Given this list of marker genes NR2F1, NWD2, SLC17A5, SLF2, VLDLR, HBEGF, NEXMIF, PLEKHG1, ZNF746 (NCBI Gene Id 155061), FRY, YTHDF1, EDEM1, POLI, WARS1, LIX1L, TMEM135, PDCL, ARFGEF1, PRR23A, IPMK (inositol polyphosphate multikinase), GRIP1, HLTF, TGFBR3, B3GNT9, MCTP1, IPO7, LANCL1, TMEM252, TMEM38B, PDE8B (NCBI Gene Id 8622), WNT3, NEUROD6, OPA3, IFNLR1, CDK12, SENP1, EMC4, KPNA2, SLC25A37, MAMDC2, CPEB3, JMJD1C, SUSD6, FBXL14, EPHA5, BAZ1A, XBP1, TBC1D8, GLT6D1, GRHL3, FAM149A, TNS3, DUSP11, CLOCK, ZMYM2, RASAL2, TKTL2, SLC1A2, PAX4, ARID4A (AT-rich interaction domain 4A), CNIH2, FBXO28, PTGES3, DKK2, PTPN20, GLG1, RALYL, PREX2, BCL7A, RFTN2, ADIPOR1, CMKLR2, BMPR2, CCNT1, RABGEF1 (NCBI Gene Id 27342), GXYLT1, NAA30 (NCBI Gene Id 122830), NUDT15, PRSS35, HSDL1, IL1RAP, ZNF714, SVIP, EDIL3, YLPM1, SYNJ1, KLHDC7B (kelch domain containing 7B), PHLDA2, ERCC8 (ERCC excision repair 8, CSA ubiquitin ligase complex subunit), RRP15, ZNF146, SEPTIN7, MYPN, MAP1B, RNF103, EN2, DCAF7, SAMD5, THSD7A, POLR3G, ZNF681, SPRY1, SBNO2, PAFAH1B1, POLB, ASPH, HNRNPK, MFAP3L, SP4, OTUD4, NFIB, HMGCS1, C1QTNF9B, H2AJ, ARFGEF2, PROX1, GCSAML, SLC13A1, SYNM, SLC16A9, KALRN, SYF2, NRCAM, TENT4A, HTR7, PHF20, ATOSA, OR2C3, WDR64, HOXB7, ZSWIM6, BAHCC1, SGK2, TMEM255A, DIAPH3, ABCA1, CNTN4, KANSL1L (NCBI Gene Id 151050), ESRRG, PIRT, PDE6D, CXCL5, RAVER2, CACNB2, GULP1, RFX6, SASH1, KIF2A, PAPSS2, EDN1, HIF1A, here is a description of the gene set: from publication Chen Y, Wang X (PMID 31504780) Human Gene Set: MIR376C_3P studied in species Homo sapiens Genes predicted to be targets of miRBase v22 microRNA hsa-miR-376c-3p in miRDB v6.0 with MirTarget v4 prediction scores > 80 (high confidence targets).